Given this list of marker genes SOS1, SNUPN, LAMA2, NHP2, PRR3, HOPX, SLC16A1, ANKLE2, CTPS1, MRPL23, RSAD2, SNRPG, EXOC3, POU2AF1 (POU class 2 homeobox associating factor 1), UTP25, SRI, CCL20, GATA3 (GATA binding protein 3), NFATC1, CUL1, LYSET, COPS8, CCT4, GTF2H4, ZW10, SQLE, RPN2, CTNNA1, GAD1, NCLN, HSPBP1, PKM, PCK2, CD63, UBE2D1, METTL13, PER2, PRMT1, RPP40, POLR2F, NFKB1, EIF4A1, MLEC, HAX1, SPRY1, MYOF, SRM, SNAPC4, CCT6A, PFAS, RNH1, SRR, YBX1, UTP18, LSM7, CLIC1, LRPPRC, CALM2, COX17, BCAT2, EIF3G, PSMD1, GNAI1, PHB1, AARS1, PDIA5, RUVBL2, BCL10, PYCR1, SEC61B, CDK4, TIMM17B, SLC29A1, KPNA2, ATP6V0A2, SLC25A5, HAUS7, CAMKK2, DHCR24, UBE2V2, ENO1, MATK, PSMA6, NUFIP1, ABCE1, CDK2AP1, GOT1, FAM98A, KDELR2, HDDC2, CANX, MGA, MAP2K3, PPP2CA, PSMB5, SNU13, FXN, RRS1, POLR2H, EMG1, PSMD7, EVI5, TM9SF1, NUTF2, DDB1, ADO, NOL7, HYOU1, RAB27A, NSMAF, COX6A1, UCHL3, FEN1, AHCYL1, GFUS, ITPA, SUCLA2, PSMG1, MARS1, HRAS, NCOR2, ZNF267, DYNLL1 (dynein light chain LC8-type 1), TFAP4, ICOS, QDPR, TRA2B, CCDC86 (NCBI Gene Id 79080), UTP3, RANBP2, ALG3, RAD1, SNHG3, LPCAT1, DHX16 (NCBI Gene Id 8449), PNP, SLC25A16, R3HDM1, GNL2, RPA3, NOLC1, GTPBP6, SPATA31C2, TXN, ADSL, UBE2S, SYNCRIP, NFE2L3, CCL4, ABCB6, MCM2, SPINT2, GLS, UTP14C, OSBPL3, SS18L1 (SS18L1 subunit of BAF chromatin remodeling complex), LCP2, TRMT1, TBCA, NDUFS6, RPA2, TOMM40, MPHOSPH6, IL18R1, RRP7A, PUM3, WARS1, HSP90AB1, SNAPC5, PLPP1 (phospholipid phosphatase 1), ZBTB24, FRMD4B, TNFSF11, HIVEP2, MBOAT7, SLA, PNO1, MIF, TNFRSF4, KLHL9, F5, TBL3, HPS5, RFC4, QPCT, SORD, ADARB1, EPRS1, PGAP1 (post-GPI attachment to proteins inositol deacylase 1), DUSP5, PRDX1, XPOT, HNRNPA0, MAMLD1, HNRNPF, GEMIN4, TXLNA, PEX3, TNFRSF9, GBP1, here is a description of the gene set: Microarray analysis was performed to determine the transcriptional profiles of NKT, CD1d-aGC+ Va24-, and CD4 T cells. Genes up-regulated in Va24- NKT cells: naïve versus activated. from publication Constantinides MG, Picard D, Savage AK, Bendelac A (PMID 21632718) species: Homo sapiens Human Gene Set: GSE28726_NAIVE_VS_ACTIVATED_VA24NEG_NKTCELL_UP